Given this list of marker genes FOXP1, AMMECR1, NRCAM, MAPRE3, BRMS1L, LIN54, CEBPB, BDNF (brain derived neurotrophic factor), RNF139, ATP2B2, PHC2, ZCCHC24, EGR1, GAP43, WWP1, TLX3, OXSR1 (oxidative stress responsive kinase 1), MAP3K12, AP1G1 (adaptor related protein complex 1 subunit gamma 1), TAF5 (TATA-box binding protein associated factor 5), NDST1, TMOD2, FZD5, AMMECR1L (NCBI Gene Id 83607), PLCD1, CCND2, TJP1, NEURL4, SOX4, here is a description of the gene set: Genes having at least one occurence of the motif TTCCGTT in their 3' untranslated region. The motif represents putative target (that is, seed match) of human mature miRNA hsa-miR-191 (v7.1 miRBase). species: Homo sapiens Human Gene Set: TTCCGTT_MIR191